Given this list of marker genes Kirrel3, Cdk5r1, Fgf2, Slc4a7, Hoxb2, Nfib, Cdk5r2, Aldh1a3, Atf2, Bcl2, Chrnb2, Kcne1, Nkx2-1, Large1, Sec24b, Fgfr3, Phox2a, Hoxb1, Cacna1a, Kcnc1, Scrib, Mecp2, Foxp2, Kcnc2, Pitx2, Hoxa1, Arx, Phox2b, Ascl1, here is a description of the gene set: studied in species Mus musculus The biological process whose specific outcome is the progression of a neural nucleus from its initial condition to its mature state. A neural nucleus is an anatomical structure consisting of a discrete aggregate of neuronal soma. Mouse Gene Set: GOBP_NEURAL_NUCLEUS_DEVELOPMENT